Given this list of marker genes Gsk3b, Dzip1, Entr1, Ccdc88a (NCBI Gene Id 77927), Efcab7, Gas8, Crocc, here is a description of the gene set: Any process that activates or increases the frequency, rate or extent of protein localization to cilium. Mouse Gene Set: GOBP_POSITIVE_REGULATION_OF_PROTEIN_LOCALIZATION_TO_CILIUM species: Mus musculus